Given this list of marker genes PCDHGA2, C9orf57, LRIG2, PLXNA4, DENND1B, CDC42EP4, PCDHGB3, STOX2, PPP1R12A, RBM14, PATJ, STIM1, PCDHGA1, UBE2I, S1PR2, CEP164, RCN1, RFX7, PCDHGA9, RB1, B4GALT2, ASTN1, RICTOR, TBC1D16, BAZ2A, GATM (glycine amidinotransferase), ERGIC1, FOXP3, PTGS2, OSBPL3, PRPF40B, HCAR3, RCSD1 (NCBI Gene Id 92241), PPM1F, ZNF366, RBFOX1, SUSD2 (NCBI Gene Id 56241), PPM1H, KCNA6, MIOS, LHFPL2, VAV3, HDHD5, RPS6KL1 (ribosomal protein S6 kinase like 1), RAB8B, PPARGC1B, RAB9B, CCND2, ORAI2, FAM217B, CSMD1, SLC26A9, MLX, NAALADL2, SERPINB2, NXF1, TREM1, ETV7, FGF4, PALD1, MCF2L, HOXA1, IL5RA, LONRF1, SRXN1 (NCBI Gene Id 140809), ANGPTL6, ERC2, NUP58, CBFA2T3, RRP36, TSPOAP1, ARB2A, KCNH1, ETNK1, SCAMP2, GPI, ZNF33B, RALGAPA2, NFATC3, ZMAT2, BAZ2B, PCNX1, MIDEAS, PABIR1, ARMC8, NKIRAS2 (NFKB inhibitor interacting Ras like 2), ZDHHC9, ZDHHC3, C12orf42, STRADA, DIRAS1, KIAA0930 (NCBI Gene Id 50610), STAU2, OMD (NCBI Gene Id 4958), CFTR, RCAN2, ZNF587, EVPL, SPRED3, ABHD17C, URM1, CD300LG, BID, KPNA3, BTBD18, PCDHGB7, GLE1, LIMK1, ZNF761, PTPRCAP, AAK1, BCL2L1, FZD3, TMEM268 (transmembrane protein 268), PCDHGA11, ACBD5, ZNF557, DNAJC19, ARHGAP42, ANGEL2, TOR4A, ENTPD4, PLEKHG4B, PCDHGA5, ARID3B, RNF213, PCDHGA10, KDM2A, CYCS, CASTOR2, CPT1B, UGGT1, MAVS, IGF1, UVRAG, ATP2B4, SRSF6, RASGRP1, ANKRD23, PCDHGA7, CRY2, CELF2, TMEM164, SLC2A10, MAGED1 (MAGE family member D1), PCDHGC3, HDAC7, PCDHGA8, HCAR2, PAG1, FIGNL2, FSTL3, RPRD1B, JADE2, DLC1, KLK4, FBRSL1, UBN1, HOXB6, ACVR2B, GNAT1, FGF5, NUDT12, DSE, KRTAP3-2, ZNF230, MLF2, CYP2U1, SGPL1, PCDHGC5, ANKRD40, ALS2CL, LUZP1, IRGQ (immunity related GTPase Q), ADAM10, PHKG2, CPEB4, ZNF276, STK40, MEF2C, SLC17A7, ZRANB2, ACVR2A, UTRN, HEYL, LENG8, LY9, ARMC1, ANGPT4, PCDHGA3, MTMR9, DDHD1, PRR14L, SGSM2, RUNX1T1, TRAPPC9, PCDHGA12, UBQLN1, SEMA6A (NCBI Gene Id 57556), MFHAS1, RHBDL3, here is a description of the gene set: Human Gene Set: MIR4649_3P species: Homo sapiens Genes predicted to be targets of miRBase v22 microRNA hsa-miR-4649-3p in miRDB v6.0 with MirTarget v4 prediction scores > 80 (high confidence targets). from publication Chen Y, Wang X (PMID 31504780)